The following is a description of a gene set: Human Gene Set: GOMF_IGE_BINDING Binding to an immunoglobulin of the IgE isotype. species: Homo sapiens, and this is the list of marker genes: MS4A2 (membrane spanning 4-domains A2), FCER1G, FCER2, LGALS3, FCER1A